Given this list of marker genes Fah, Atp2b4, Oat, Nos2 (nitric oxide synthase 2, inducible), Nos1, Arg1, Arg2, Ddah1, Nos3, here is a description of the gene set: The chemical reactions and pathways resulting in the breakdown of arginine, 2-amino-5-(carbamimidamido)pentanoic acid. studied in species Mus musculus Mouse Gene Set: GOBP_ARGININE_CATABOLIC_PROCESS